Given this list of marker genes FURIN, TIMP2, ERAP1, ADAM10, BACE1, ADRA2A, TSPAN15, RGMA, IL10, APH1A (aph-1 homolog A, gamma-secretase subunit), LRIG2, PSENEN, SPPL2B, ADAM8, PSEN2, MYH9, HM13, SPPL2C, ROCK1, SNX9, TNF, PACSIN3, TSPAN17, IFNG, SH3D19, DAG1, CWH43, SNX33, RBMX, GPLD1, NRDC, SPPL2A, APP, TSPAN5, ADAM19, ADAM9, TIMP3, ADAM17, PTPN3, PRTN3, P2RX7, PRKCQ, TIMP1, BACE2, PSEN1, SPPL3, IL1B, APOE, TNFRSF1B, NCSTN, TIMP4, MMP7, here is a description of the gene set: Human Gene Set: GOBP_MEMBRANE_PROTEIN_ECTODOMAIN_PROTEOLYSIS species: Homo sapiens The proteolytic cleavage of transmembrane proteins and release of their ectodomain (extracellular domain).